Given this list of marker genes HLA-C, AIRE, MSX1, TINF2, FOXN1, TERC, IKBKG, TERT, UFC1, TP63, LPAR6, KLK11, here is a description of the gene set: Human Gene Set: HP_NAIL_PITS Nail pits species: Homo sapiens Small (typically about 1 mm or less in size) depressions on the dorsal nail surface.